Given this list of marker genes VAC14 (NCBI Gene Id 55697), ZNF576, SORT1, OXSM, TMED7-TICAM2, MEF2C-AS2, KIAA0930, RNU6-1, ZNF271P, LINC00882, SIK2, CD55 (CD55 molecule (Cromer blood group)), ARPC5L, PIK3R1, MRPS31, TLE5, BRF1, CPN2, RHEX, TLE6, KEAP1, LRRC25, TSPAN10, AIF1L, TPM4, MSH5-SAPCD1, CCNY, GADD45A, LAPTM5, TTC1, TMCC2 (transmembrane and coiled-coil domain family 2), GUSBP1, OCLN, TBX3, C16orf74, ATP5PD, OTX1, ZDHHC12, BZW2, NDNF-AS1, CNGB1, ENSG00000233251, GLS2, ANKRA2, ANKMY1, DPF1, ARNT, HOXA11-AS, ITGAL-AS1, DHRS13, SERPINB1, GRIN3B, ABHD13, POLN (DNA polymerase nu), BBX, RICTOR, EPHB3, BCL7B, RNF32, TTC39A, AKT1, MGAT2, RPL39P38, TPD52L2, CLDN16 (claudin 16), RNF32-DT, AKT1S1, MACROD1, LNP1, ZNF404, SCUBE1-AS1, TTI2, EHD1, ZMIZ1-AS1, SHOX2, PARVG, LINC02018, OCEL1, ARIH1, TCF3, CGB5, KRT18P12, LINC00339, ZNF790, IL17RC, FCHO1, NDUFV2, SCAND3, EML2, RDH13, LLGL1, HHIPL1, DOC2A, ANXA6, DLEU1, MIR663AHG, DUBR, TMEM44, CUX1, RCOR1, HOXC-AS1, CNNM1, CYP3A51P, FAM86DP, CYB5R3, WFDC21P, VANGL1, ZDHHC21, LIG4, ADSL, GDI2, MAP1S, ELN-AS1, SRRM5, MTFMT, CMIP, SRFBP1, FBXL15, RNA5SP48, COLEC11, WARS1, DUS3L, ECE1, CGB8, CNGA4, RN7SL446P, CROCCP3, RBCK1, FLII, IRX3, GTF2F1, PPP1R13L, NLE1, CGB3, SLC35E1, ZSCAN25, MRPS10, PHACTR2-AS1, SLC6A12, ZBTB7C, IL4R, TGFBR2, KICS2 (KICSTOR subunit 2), MKRN2OS, TMEM54, MAPK8IP3, ABCA7, UCP2, TES, ESCO1, SH3BP2, MARK1, FBN3, PRKAR1B, ZBTB11-AS1, ENSG00000267024, MAST3, ZNF536, PAXBP1, NUP155, HIC1, DESI2, SAMD14 (NCBI Gene Id 201191), ALG8, KLHDC9, MTO1, SERPINF1, ZSCAN30, ANKRD24, PBX1, GPN3, PREB, HEATR3, PRDM6-AS1, CYP3A5, NHSL1, TCF7L2, LINC00620, NIBAN3, G3BP2, ZNF45-AS1, PDE4C, ENSG00000267058, SLAMF8, ATP5MC3, C10orf95, ZBTB16, MED21, RB1, MYOZ3, CAD, SRPK1, BSN, WDR31, NDUFV3, NPLOC4, LMLN, KCNK1, WDR19, SNAP23, ASH1L, ZNF296, FAM199X, PSD, KCTD21-AS1, RHOU, CELF4, MRPL39, PRDM6, NHSL1-AS1, ZNF362, DHRS3, CAND1, NOL6, CRISPLD2, ARHGAP45, HAUS3, MIR4665, ANKRD13D, FUT6, GAB1, L3MBTL1, CREB5, HOXC9, CLDND1, PAPLN, COL13A1, BEST1, TENT4B, SLC35E2A, NGLY1, MEOX1 (mesenchyme homeobox 1), TAF6, CEP89, CEMIP2, STAMBPL1, TARBP2 (TARBP2 subunit of RISC loading complex), TFAP2A, CCNT1, TMED7 (transmembrane p24 trafficking protein 7), CAPS2, PCDH9, RFC4, ASXL3, NAT14, SLC22A18, RMND5B, LZTS2, MAU2, MST1P2, CNPY4, POLR1G, GTPBP3, FES, CCL22, KCNQ2, ENSG00000259200, CASTOR3P, CACNA2D4, LINC01686, TSHZ2, TYSND1, ZC3H14, WDR25, INO80D-AS1, MIR3189, TLL2, RBMS2, ARCN1, FRS2, CCDC97, C3, SLC4A2, TTC19, IQCG, PNKP, FAM216A, ZSWIM7, TBC1D17, ZFP90, TXN2, EPCIP-AS1, ZKSCAN2, SUSD3, CEP95, PFAS, LRP8, MIR1249, TIMM44, PTPN2, ACTG1, CHST12, FAM43A, ENC1, SLC25A37, NRXN3, UBA2, FUT5, MSH5, DDX5, SLC25A3P1, LINC02868, LONP2, SDR39U1, CNN2, CIRBP, GOLGA5, DEGS2, RPL22, ISL2, R3HDM4, MIEF1, TBX1, IRGQ, C19orf25, POU2F2, ADH5 (alcohol dehydrogenase 5 (class III), chi polypeptide), ST6GALNAC3, POLR2G, LINC01363, CROCCP2, ISYNA1, KDM8, STAT6, PISD, TBXA2R, CWC25, SMAD3, TUBB3, AGAP3, ZNF345, STOML3, PHLDA2, KIF1B, FSD1, NCKAP1L, GTF2F2, LRRK2-DT, CYTH4, LIN52, RNU7-94P, SNTA1, SPRED2, FAAP24, CHROMR, PDZD2, VPS37D, BRWD3, PTPRS, LSM3P4, GDF15, TRIM15, RPL23P2, ADAR, UTP14A, ENSG00000272195, PRRT2, LRRK2, PIK3R2, SIAH1, RND1, here is a description of the gene set: studied in species Homo sapiens Human Gene Set: ZFP3_TARGET_GENES Genes containing one or more binding sites for (ZFP3) in their promoter regions (TSS -1000,+100 bp) as identified by GTRD version 20.06 ChIP-seq harmonization. from publication Yevshin I, Sharipov R, Kolmykov S, Kondrakhin Y, Kolpakov F (PMID 30445619)